Given this list of marker genes MIR208A, IGF1, AKAP6, TOMM70 (translocase of outer mitochondrial membrane 70), PARP2, G6PD, MIR24-1, GSK3A, MIR195, YY1, MIR19A, SORBS2, NPPA, ADRA1A, MIR199B, MIR23A, MIR199A1, EDN1, MEIS1, PDLIM5, FOXP1, PPARA, PI16, GATA4, CAV3, CTDP1, RGS2, COL14A1, PRKG1, PAK1, RGS4, MIR19B1, here is a description of the gene set: Human Gene Set: GOBP_PHYSIOLOGICAL_CARDIAC_MUSCLE_HYPERTROPHY species: Homo sapiens The enlargement or overgrowth of all or part of the heart muscle due to an increase in size of cardiac muscle cells without cell division. This process contributes to the developmental growth of the heart.